The following is a description of a gene set: The directed movement of sterols into, out of or within a cell, or between cells, by means of some agent such as a transporter or pore. Sterols are steroids with one or more hydroxyl groups and a hydrocarbon side-chain in the molecule. Mouse Gene Set: GOBP_STEROL_TRANSPORT studied in species Mus musculus, and this is the list of marker genes: Sirt1, Tsku, Apoe, Trem2, Msr1, Vps52, Abcg1, Stard5, Pparg, Commd1 (NCBI Gene Id 17846), Spg11, Washc1, Egf, Lcat, Ttc39d, Lamtor1, Npc1, Vps51, Gramd1a, Comt, Arv1, Abca7, Osbpl2, Osbp, Abca1 (NCBI Gene Id 11303), Lipa, Hnf1a, Arl8b, Sec24a, Ces1e, Ces1g, Cftr, Apoa4, Abca8a, Abcg5, Gramd1c, Gpihbp1, Abcg4, Vps4b, Stard4, Apoa2, Gramd1b, Scp2, Anxa2, Nr1h3, Furin, Abca12, Abca8b, Apoc1, Mexis, Naxe, Lrp6, Pip4k2a, Soat2, Vapb, Npc1l1, Apoc3, Osbpl6, Serac1, Mttp, Apom, Cav1, Nr1h2, Star, Relch, Vps53, Vapa, Ces1c, Stard3, Ldlrap1, Apob, Stx12, Pla2g10, Adipoq, Ptch1, Pon1, Snord60, Pcsk9, Ces1a, Apoc2, Abca13, Tpcn2, Gps2, Ldlr, Ttc39b, Eepd1, Nus1, Lipc, Vps54, Nfkbia, Yjefn3, Ces1b, Scarb1, Tmem97, Soat1, Shh, Ces1d, Npc2, Tspo2, Cd36 (CD36 molecule), Abca5, Syt7, Abcb4, Abcg8, Apoa5, Ces1h, Srebf2, Pltp, Lipg, Abca2, Nfkb1, Irak1, Vps4a, Abca3, Ces1f, Apoc2l, Apoa1, Lrp1, Stard3nl, Apof, Zdhhc8